The following is a description of a gene set: from publication Nakaya HI, Wrammert J, Lee EK, Racioppi L, Marie-Kunze S, Haining WN, Means AR, Kasturi SP, Khan N, Li GM, McCausland M, Kanchan V, Kokko KE, Li S, Elbein R, Mehta AK, Aderem A, Subbarao K, Ahmed R, Pulendran B (PMID 21743478) species: Homo sapiens Human Gene Set: GSE29615_CTRL_VS_DAY3_LAIV_IFLU_VACCINE_PBMC_UP Systems vaccinology has emerged as an interdisciplinary field that combines systems wide measurements and network and predictive modeling applied to vaccinology. Here we used the systems vaccinology approach to study the molecular mechanisms underlying the innate responses to the trivalent inactivated influenza (TIV) and live attenuated influenza (LAIV) vaccination in humans, and to identify early gene signatures that predict the magnitude of the antibody responses to influenza vaccination. Genes up-regulated in comparison of peripheral blood mononuclear cells (PBMC) from LAIV influenza vaccinee pre-vaccination versus those at day 3 post-vaccination., and this is the list of marker genes: NXF2, KBTBD8, BRAF, CYB5R2, IFNA17, RAE1, GRM2, DPM1, PRSS33, ARIH2 (NCBI Gene Id 10425), ROPN1B, PPRC1, RAP2C, MMP25, LYVE1, MZT1, TFG, LIMK2, PRPF40A, FAM53C (family with sequence similarity 53 member C), B3GNT2, LAPTM4A, RPS3A, IFIT5, SPRR4, EPHA8, SERPING1, TBC1D15, VPS37B, THBD, MMADHC, FAM8A1, UGT2B28, SLC25A39, MTMR6, CELF4, SYF2, PEX13, COX7A2, KCNJ15, TBPL1, CAMKK1, EMC6, ENSG00000250685, TXNDC16, ACOT12, MRGPRX3, ZDHHC18, BBOF1, DPYSL3, USP30, TGIF2, SAMSN1, CRY1, PCDHB6, YPEL5, SAMD15, DCP1A, RNF212B, MBOAT7, GNG12, NDEL1, MBIP, YTHDF3, KBTBD2, ITPRID2, ACTL7A, ZNF24, CREBRF, SGTB, ZNF586, FBXW5, CCR3, RAB30, PI4K2A, BRIX1, MNT, CLEC2B, HSPA13, MED30, SLC45A4, RAMP2, GTF2B, GRTP1, RAB11FIP4, KCNV1, PNPLA8, ZFP36L1, LCE2B, DACH2 (NCBI Gene Id 117154), CCDC85C (NCBI Gene Id 64758), BCLAF1, TNFAIP6, COIL (NCBI Gene Id 96825), PCDHGA10, ESCO1, MAP3K2, PEX12, GNA13, GAL3ST3, ATG2A, GGT2P (NCBI Gene Id 91203), DUSP10, ABHD17C, WNK4, CCNG2, DHX9, COQ10B, VAPB, PHF13, ANKRD22, PLEKHA3, BACE2, IGHV7-81, TLE4, STRAP, TFAM, MYOD1, PCIF1, LHX6, HBB, TOMM70, FBXL3 (F-box and leucine rich repeat protein 3), DNAJB9, CHMP2B, CNEP1R1, CRYAB, SUCO, CHD1, ABHD13, TMEM45B, LINC01348, CARMIL1, RCL1, ZNF598, SLC34A2, SIPA1L2, LONRF1, PRC1, MAPK6, RASGEF1B, CXCL1, PML, OLFM1, TIGAR, SLC25A28, ADGRG3, ERO1A, KRT78, METTL16, AFAP1L2, LAMP3, ETF1, FFAR2, SPTY2D1, C15orf39, NUP98, DTL, ANXA3, TLK2, RAB1A, TOPORS, PPP2CA, TMEM11, HNRNPH2, IP6K2, ALPK3, B3GNT5, MAGOHB, MMP12, HMGXB4, TMEM167B, ZNF770, NUDT15, MKNK2, ZNF644, ZRANB1, ING3, VNN3P, MN1, ANKRD52, SNX4 (sorting nexin 4), CCDC28A, FYTTD1, PPP4R2, GABARAPL1 (NCBI Gene Id 23710), DNTTIP2, SUMO1, DDA1, RBP1, RAB2A